Given this list of marker genes Prr7, Polr2a, Lyar, Dhx33, Ncl, Wdr43, Cebpa, Polr3b, Macroh2a1, Polr1b, Tcof1, Ddx11, Dedd, Mtor, Polr1e, Crebbp, Smarca4, Polr1h, Smarcb1, Cavin1, Taf1a, Polr2e, Rasl11a, Baz2a, Ercc2, Nol11, Maf1, Baz1b, Nop53, Sirt7, Polr1f, Ddx21, Heatr1, Phf8, Eif2ak3, Mybbp1a, Ubtfl1, Pih1d1 (NCBI Gene Id 75728), Dek, Polr1d, Polrmt, Polr2b, Ippk, Wdr75, Taf1b, Erbb2, Utp15, Atf4, Flna, Ttf1, Polr1c, Pdcd7, Polr2f, Actr6, Ppp1r15a, Macroh2a2, Rrn3, Taf1c, Polr1a, Gtf2h1, Tbp, Spty2d1, Bnc1, Pwp1, Ercc3, Gtf2h5, Mars1, Ubtf, Polr2l (polymerase (RNA) II (DNA directed) polypeptide L), Myo1c, Lipe, Smarca5, Polr1g, Sf3b1 (splicing factor 3b, subunit 1), Ercc6, Zmpste24, here is a description of the gene set: studied in species Mus musculus Mouse Gene Set: GOBP_TRANSCRIPTION_BY_RNA_POLYMERASE_I The synthesis of RNA from a DNA template by RNA polymerase I (RNAP I), originating at an RNAP I promoter.